Given this list of marker genes Shroom2, Zbtb10, Entpd6, Tmem50b, Prdm1, Tet2, Adamts6, Gm3604, Xpo1, Ewsr1, Psmc6, Mnat1, Gpm6a, Pld1, Fezf1, Pramel60, Kcnc2, Lmtk2, Nexmif, Atxn1, Zscan29, Septin3, Atg12, Myocd, Ms4a1, Atp1b1, Gimap6, Spag9, Tshz3, Manbal, Ssr1, Pfpl, Sptbn1, Nme7, Poc1b, Tslp, Zfyve19, Dnm3, Aldh1l1, Ncbp1, Stmn2, Ubfd1, Brsk2, E2f6, Ccdc60, Rps6kb1, Ctnnbl1, Zfp275, Tspan4, Fzr1, Ophn1, Kif4, Cdh13, Hip1, Csdc2, Pias1, Txlna, Map3k2, Gprasp2, Mpp4, Rgs4, Sntn, Otud6b, Gsto1, Zfp507, Ric8b, Tchp, Stx8, Tpm1, Ezr, AU018091, Rest, Zbtb6, Tmem167 (NCBI Gene Id 77129), Fbn2, Snca, Atad2b, Hp1bp3, Upf1, Hexb, Zim1, Prame62, Cd226, Zfp493, 1700066M21Rik, Map4, Wdfy1, Gls, Sgms1, here is a description of the gene set: species: Mus musculus from publication Chen Y, Wang X (PMID 31504780) Genes predicted to be targets of miRBase v22 microRNA mmu_miR_7001_3p in miRDB v6.0 with MirTarget v4 prediction scores > 80 (high confidence targets). Mouse Gene Set: MIR_7001_3P